Given this list of marker genes SUGCT, KIF1B, SUCLA2, CD320, TAMM41, L2HGDH, PPOX, LETM1, ETFB, SLC13A3, DHTKD1, MCEE, SLC18A2, FBXL4, TAT, GCDH, KYNU, TRMU, ETFA, HGD, UROS, HPD, ALAD, SLC52A1, SLC25A20, HADH, MRPL39, TCN2, PAH, SCO1, FDFT1, AGXT, CPT1A, GATA1, UROC1, COQ4, ETHE1, OXCT1 (3-oxoacid CoA-transferase 1), HCFC1, MTRR, LIN28B, ACADSB, TFAM, POLG, SLC22A5, ACSF3, MYCN, ALK, HSPD1, ECHS1 (NCBI Gene Id 1892), ABCD4, CPOX, ACADS, FOCAD, D2HGDH, MLYCD, DDC, ALDH6A1, PRDX1, ETFDH, ACAD8, ACAD9, MVK, MMADHC, MMAB, HACE1, FH, SLC6A19, PHOX2B, MMACHC, CPT2, RET, LMO1, HMBS, MMUT, ALDH4A1, IDH1, HLCS, SLC25A1, SUCLG1, ACADM, FTCD, MTR, NDUFS4, IDH2, PEX14, CA5A, MCCC1, HMGCS2, BCKDHA, GRHPR, MMAA, NDUFB10, LMBRD1, COX16, ALDH5A1, SFXN4, NFU1, ACADVL, HMGCL, UPB1, here is a description of the gene set: An increased amount of carboxylic acid in the urine. Elevated urinary carboxylic acid species: Homo sapiens Human Gene Set: HP_ELEVATED_URINARY_CARBOXYLIC_ACID